Given this list of marker genes Ddx1, Tpm1, Acta1, Actc1, Eprs1, Hsp90aa1, Eif3c, Car2, Nefl, Pdia3, Peg3, Sars1, Ddx24, Ddx21, App, Psmc1, Dnaja1, Sfn, Krt8, Anxa3, Wnt3, Numb, Id3, Hmga2, Qki (quaking, KH domain containing RNA binding), Lxn, Anxa5, Rock2, Got2, Ckb, Dlg1, Eif2s1, Arf1, Tuba1a (NCBI Gene Id 22142), Tfap2c, Rpa2, Acta2, Ddx3x, Rit1, Atp6ap1, Wars1, Sptan1, Psmc2, Vim, Fgfr1, Tagln, Fgfbp1, Stam, here is a description of the gene set: Genes down-regulated in embryonic stem cells with BRCA1 loss of function (LOF). from publication Aprelikova O, Pace AJ, Fang B, Koller BH, Liu ET (PMID 11384963) Mouse Gene Set: APRELIKOVA_BRCA1_TARGETS BRCA1 gene is a tumor suppressor for breast and ovarian cancers with the putative role in DNA repair and transcription. To characterize the role of BRCA1 in transcriptional regulation, we analyzed gene expression profiles of mouse embryonic stem cells deficient in BRCA1 using microarray technology. We found that loss of BRCA1 correlated with decreased expression of several groups of genes including stress response genes, cytoskeleton genes, and genes involved in protein synthesis and degradation. Previous study showed that BRCA1 is a transcriptional co-activator of p53 protein; however the majority of p53 target genes remained at the same expression levels in BRCA1 knockout cells as in the wild type cells. The only p53 target gene down-regulated with the loss of BRCA1 was 14-3-3 sigma, a major G(2)/M checkpoint control gene. Similar to cells with decreased 14-3-3 sigma activity, BRCA1-deficient cells were unable to sustain G(2)/M growth arrest after exposure to ionizing radiation. We find that BRCA1 induction of 14-3-3 sigma requires the presence of wild type p53 and can be regulated by a minimal p53 response element. species: Mus musculus